Given this list of marker genes CLCF1, HPX, CR1, TREM2, TGFB1, SHLD2, IL10, CD40, FCGR1A, RIF1, HMCES, C3, EXOSC6, TNFSF13, ATAD5, MLH1, FOXJ1, MSH2, BTK, SUSD4, FCER1G, C4BPB, FCGR2B, NSD2, EXOSC3, SLC15A4, CR1L, SHLD1, C17orf99, TNFSF4, HLA-E, NDFIP1, PAXIP1, C4BPA, TNF, SHLD3, PTPRC, PMS2, FOXP3, IL4, NECTIN2, BCL6, TBX21, CR2, KMT5C, SUPT6H, CD46, APLF, PTPN6, TP53BP1 (tumor protein p53 binding protein 1), IL27RA, MAD2L2, FCER2, KMT5B, TFRC, IL2, XCL1, CD226, CD28, LTA, STAT6, PARP3, here is a description of the gene set: Any process that modulates the frequency, rate, or extent of B cell mediated immunity. species: Homo sapiens Human Gene Set: GOBP_REGULATION_OF_B_CELL_MEDIATED_IMMUNITY